The following is a description of a gene set: studied in species Homo sapiens Human Gene Set: HP_APLASIA_HYPOPLASIA_INVOLVING_THE_FEMORAL_HEAD_AND_NECK Aplasia/Hypoplasia involving the femoral head and neck, and this is the list of marker genes: MTX2, CTC1, POC1A, IFT140, SHOX, CANT1, EXOC6B, PEX5, B3GALT6, XYLT1, TRPV4, RAD21, BMPR1B, DDRGK1, AIFM1, CFAP410, LBR, MEG3, MBTPS1, FGFR3, COL2A1, CCN6, RTL1, TRAF3IP1, DLK1, RUNX2, CHD4, CHST3, COMP, MMP9, FN1, TRAPPC2, RSPRY1, GNPNAT1, TMEM67, IFNGR1, POP1, SLC26A2, COL9A1, IHH, SLC10A7, MATN3, PRG4, SLC39A13, IDUA, PIK3C2A, NANS, TONSL